The following is a description of a gene set: Any process that modulates the frequency, rate or extent of telomere maintenance in response to DNA damage. species: Mus musculus Mouse Gene Set: GOBP_REGULATION_OF_TELOMERE_MAINTENANCE_IN_RESPONSE_TO_DNA_DAMAGE, and this is the list of marker genes: Actr8, Actr5, Ruvbl2 (NCBI Gene Id 20174), Tfpt, Ruvbl1, Ino80c, Ino80b, Ercc4, Mcrs1, Xrcc1, Ercc1, Rtel1, Ino80d, Ino80 (NCBI Gene Id 76476), Xrcc4, Nfrkb, Actl6a, Uchl5, Yy1 (NCBI Gene Id 22632)